Given this list of marker genes DNM2, DNM1, CLTC, GJA1, ACTB, ACTG1, AP2M1, CLTA, DAB2, CLTCL1, CLTB, here is a description of the gene set: part of: Gap junction degradation studied in species Homo sapiens Gap junction plaque internalization and the disruption cell communication requires a reorganization of Cx molecular interactions. Proteins including Dab-2, AP-2, Dynamin and Myosin VI associate with gap junction plaques permitting the internalisation of plaques after clathrin association. Until now, two kinds of annular gap junctions have been described. The first is a small vesicle like structure which permits gap junction plaque renewal without arrest of functionality. The second is a large annular structure, composed primarily of the junctional plaques of two adjacent cells. Reactome Pathway: Formation of annular gap junctions